Given this list of marker genes HAUS5, DCTN1, TUBB2B, CDK5RAP2, TUBA1B, TUBA3E, TUBA3C, DYNLL1 (dynein light chain LC8-type 1), TUBGCP3, TUBB2A, TUBB3, DYNC1H1, NEK2, HAUS4, YWHAG, CEP290, PCNT, TUBA4B (tubulin alpha 4b), CEP131, NUMA1, NME7, NINL, PPP2R1A, PCM1 (pericentriolar material 1), CEP135, PLK4, CEP57, PLK1, CEP164, CDK1, AKAP9, CEP192, TUBA1C, CEP76, ALMS1, TUBA4A, SFI1, TUBA3D, PRKACA, YWHAE, TUBG2, TUBGCP5, TUBA8, NEDD1, HAUS7, TUBB6, MZT2A, MAPRE1, DCTN2, CEP70, SSNA1, TUBB4A, DCTN3, MZT2B, TUBB8, DYNC1I2, CEP152, CEP78, HAUS8, CEP43, CEP41 (centrosomal protein 41), PAFAH1B1, HAUS6, MZT1, ACTR1A, CSNK1D, HAUS3, CEP250, TUBGCP2, TUBA1A, TUBGCP6, SDCCAG8, TUBB, TUBGCP4, CEP63, TUBG1, CSNK1E, NDE1, CKAP5, TUBB1, CLASP1, ODF2, TUBB4B, CETN2, PRKAR2B, HAUS2, TUBAL3, OFD1, CENPJ, TUBB8B, CCP110, CEP72, HSP90AA1, HAUS1, CNTRL, here is a description of the gene set: Recruitment of NuMA to mitotic centrosomes studied in species Homo sapiens Human Gene Set: REACTOME_RECRUITMENT_OF_NUMA_TO_MITOTIC_CENTROSOMES